Given this list of marker genes APMAP (adipocyte plasma membrane associated protein), CA1, PON3, CA2, PON2 (paraoxonase 2), PON1, here is a description of the gene set: Human Gene Set: GOMF_ARYLESTERASE_ACTIVITY Catalysis of the reaction: a phenyl acetate + H2O = a phenol + acetate. species: Homo sapiens